The following is a description of a gene set: Human Gene Set: HP_SLEEP_WAKE_CYCLE_DISTURBANCE studied in species Homo sapiens Sleep-wake cycle disturbance Any abnormality of an individual's circadian rhythm that affects the timing of sleeping and being awake is referred to as a sleep-wake disorder., and this is the list of marker genes: ADRB1, NODAL, PER2, DISP1, CSNK1D, OCA2, KIF15, DHCR7, RAI1, FGFR1, PER3, GAS1, SMC1A, SNRPN, PRNP, UBE3A, GNS, DEAF1, CRIPTO, CHD8, STIL, CAMK2A, CDKL5 (NCBI Gene Id 6792), TAF1, FGF8, ZIC2, SHH (NCBI Gene Id 6469), ATP10A, PSEN2, DLL1, SIX3, GRIA3, STAG2, PTCH1, FBXL3, WBP4, TIMELESS, PLCH1, GLI2, TGIF1 (TGFB induced factor homeobox 1), CDON, IQSEC2, APOE, TELO2, FOXH1, FLII, GABBR2